Given this list of marker genes Itgal, Myh9, Psmb9, Pfdn5, Cotl1, Fth1, Ptpre, Nsmce1, Ankrd44, Mxd4, Sorl1, Efhd2, Mapre2, Ctsd, Stard10, Itga2, Crot (carnitine O-octanoyltransferase), Rbms1, Vim, Dgka, Glipr2, Cd27, Arhgap45, Dock2, Btg1, Selplg, Ccr2, Ets1, Jakmip1, Neat1, Sp100, Sh3bgrl3, Celf2, Slfn2, Olfm1, Pcmtd1, Klf13, Ms4a4b, Il10rb, Prkacb, Capn2, Rhoa, Cd48, Txk, Zbtb38, Nkg7, Arl5c, Klrb1b, Sipa1, Plp2, Lat2, Arid5a, Pag1, Zfp36l2, Klrc1, Fos, Anxa1, Cd200r4 (NCBI Gene Id 239849), Skap1, Ankrd11, Ptprc, Klf2, Tespa1, Zyx, Slc12a6, Itgb7, Sla, Nr4a2, Peli1, Jun, Ppp1r18, Anxa2, Trim12c, Pkp3 (NCBI Gene Id 70182), Ctdsp2, Adgre5, Hes6, Fmnl1, Lyst, Mindy2, H2-T23, Srpk2, Pold4, Pycard, AI467606, Septin1, Psap, Zbtb20 (NCBI Gene Id 80492), Ctsw (cathepsin W), Flna, Jund, Tbc1d10c, S100a11, Tmem59, Arsb, Irf2bpl, Car2, Tm6sf1, Dusp1, Coro1a, Gabarap, Agtrap, Hopx, Il2rb, Arid5b, Tnfaip8l2, Mical1, Atxn7l1, Rchy1, As3mt, Lrrfip1, Sptbn1, Wls, Tln1, Ccl5, Lck, Uqcrh, Lppos, Tagln2, Lrrc8c, Tax1bp1, Iqgap2, Klre1, H2az1, Zfp36, Klf6, Commd8, Ifngr1, Klhl6, Samd3, Cdc42ep3, St3gal6, Ltb, Tspan32, Neurl3, Utrn, Crybg1, Ech1, Tle5, Mylip, Cdc42, Tecpr1, Arl4c, Xist, Heca, Ikzf3, Pbxip1, Elf1, Eif3f, Macf1, Aoah, Actg1, Stim1, Cyfip2, Rinl, Id2, AB124611, Fau, Spn, Ucp2, Ptpn18, Emp3, Git2, Tbx21, Ifi209, Card19, Plaat3, Emb, Atp2b1, Selenop, Pea15a, Qrfp, Atp11b, Arl6ip1, Tpm1, Mxd1, Myl6, Klrd1, Ccnd3, Ptbp3, Ube2h, Klf3, Epsti1, Prkcq, Myo1f, Plec, Bin1, Cap1, Smad7, Hcst, Add3, Dap, Arid4b, Pitpnc1, Ipcef1, Kmt2e, Atp2b4, Lax1, Itm2b, S1pr4, Arpc2, Ppp1r12a, Map1lc3b, Ripor2, Cox7a2l, Fgl2, Junb, Fam111a, Cnp, Dennd1c, Ccdc82, Calm1, Pik3r1, Ftl1, Sell, Nfatc2, Samhd1, Cd53, Shisa5, Arpc3, Lrrk1, Traf3ip3, Malt1, Scand1, Leprotl1, Ifi203, Sema4a, Ddit3, Tspo, Fcer1g, Maf, Cd247, S100a10, Pdcd4, Rasgrp2, Gmfg, Rsrp1, Sh2d3c, Trim12a, Adcy7, Esyt1, Twf2, Arhgap9, Ahnak, Cd37, Stat4, Lbh (NCBI Gene Id 77889), Stk17b, Inpp5d, Klrb1a, Kif21b, Sesn3, Sat1, Fcgr3, Vamp8, Abcg1, Samd9l, Ptms, Fxyd5, Atp6v1d, Ctla2a, Spry2, Prr13, Fyn, Btg2, Clk1 (NCBI Gene Id 98487), Ssh2, Ptpn22, Cyth4, Serinc3, Aak1, Cd28, Cnn2 (NCBI Gene Id 12798), Itm2a, Tut4, Gnai2, Rbpms, Iqgap1, Gpx4, Tnrc6b, Ier2, Il18rap, Pde7a, Pglyrp1, Cast, Add1, Cd84, Crip1, Evl, Cbl, Bin2, Reep5, Il18r1, Tnfsf12, Trbc1 (T cell receptor beta, constant region 1), Rasa3, Itpr2, Abr, S100a13, Atp1b1, Ndufb11, Jak1, Rgs2, Gprin3, Eomes, Tsc22d3, Gem, Pnrc1, S100a6, Prex1, Tpm4, Bcl2, Myl12b, Arrb2, Cd47, Tsc22d4, Actr3, Fcho2, Tmsb10, Ifi208, Cd2, Tyrobp, H2-D1, Smpdl3a, 9930111J21Rik2, Cdkn2d, St8sia4, H2az2, Ccr5, Lat, Ogt, Ablim1, Rabac1, Ifi206, Fosb, Klrk1, Entrep3 (endosomal transmembrane epsin interactor 3), Gzma, Pitpnm1, Nlrc3, Ypel3, Arhgef1, Hsd11b1, Tuba1a, Tmbim6, Rasal3, Anxa6, Tmem234, Itgam, Cd7, Klrc2, Phf1, Cytip, Saraf, Gnb2, Npc2, Arhgef18, Ndufv3, Fasl, Zbp1, Gpsm3, Klrb1c, Hmgb2, Cdkn1b, Mbnl1, Klra8, Il7r, Txnip, Sytl2, Tmem50a, Arhgap15, Arhgdib, Clic1, Helz, Cxcr3, Stk24, Tnik, Irf2, Mrtfa, here is a description of the gene set: from publication Cui A, Huang T, Li S, Ma A, Pérez JL, Sander C, Keskin DB, Wu CJ, Fraenkel E, Hacohen N (PMID 38057668) Cytokines mediate cell-cell communication in the immune system and represent important therapeutic targets. A myriad of studies have highlighted their central role in immune function, yet we lack a global view of the cellular responses of each immune cell type to each cytokine. To address this gap, the authors created the Immune Dictionary, a compendium of single-cell transcriptomic profiles of more than 17 immune cell types in response to each of 86 cytokines (>1,400 cytokine-cell type combinations) in mouse lymph nodes in vivo. A cytokine-centric view of the dictionary revealed that most cytokines induce highly cell-type-specific responses. For example, the inflammatory cytokine interleukin-1β induces distinct gene programmes in almost every cell type. A cell-type-centric view of the dictionary identified more than 66 cytokine-driven cellular polarization states across immune cell types, including previously uncharacterized states such as an interleukin-18-induced polyfunctional natural killer cell state. studied in species Mus musculus Mouse Gene Set: CUI_NK_CELL_IL18_RESPONSE_DN Genes negatively differentially expressed in cell type: NK cell upon treatment with cytokine: IL-18 in mouse lymph nodes in vivo.